The following is a description of a gene set: species: Mus musculus Any process that modulates the frequency, rate or extent of CD4-positive, alpha-beta T cell activation. Mouse Gene Set: GOBP_REGULATION_OF_CD4_POSITIVE_ALPHA_BETA_T_CELL_ACTIVATION, and this is the list of marker genes: Il2ra, Nfkbiz, Cd160, Il2rg, Kcnk18, Cd274, Gimap3, Cd24a, Socs1 (suppressor of cytokine signaling 1, NCBI Gene Id 12703), Rc3h1, Cd81, Zbtb7b, H2-Ea (histocompatibility 2, class II antigen E alpha), Brd4, Tarm1, Hlx, Ccr7, Rara, Tnfrsf14, Cd44, Ep300 (E1A binding protein p300), Anxa1, Nfkbid, Jak3, Zc3h12a, Nlrp3, Tnfsf18, Irf1 (interferon regulatory factor 1), Bcl6, Ndfip1, Cd3e, Brd2, Ccl19, Zfp35, Il27, Cd55, Ccr6 (C-C motif chemokine receptor 6), Ager, Prkcz, Opa1, Pf4, Ccr2 (NCBI Gene Id 235692), Hmgb1, Lgals9, Nckap1l, Cblb, Il6 (interleukin 6), Il2, Cd69, Itch, Loxl3, Lgals1, Tgfbr2, Arg2, Gimap5, Runx3, Cd28, Cd83, Cd55b, Tbx21, Klhl25, Malt1, Socs5, Shb, Card11, Irgm1, Ripk2, Twsg1, Il4ra, Gata3, Mir301, Sh3rf1, Mir326, Ccl20, Il23a, Xcl1, Tgfb1, Ifng, Il18, Cbfb, Foxp3 (forkhead box P3), Prkcq, Il4, Tnfsf4, Sash3, Vsir, Ascl2, Rc3h2, Runx1, Smad7